The following is a description of a gene set: Reactome Pathway: Interleukin-1 family signaling part of: Signaling by Interleukins studied in species Homo sapiens The Interleukin-1 (IL1) family of cytokines comprises 11 members, namely Interleukin-1 alpha (IL1A), Interleukin-1 beta (IL1B), Interleukin-1 receptor antagonist protein (IL1RN, IL1RA), Interleukin-18 (IL18), Interleukin-33 (IL33), Interleukin-36 receptor antagonist protein (IL36RN, IL36RA), Interleukin-36 alpha (IL36A), Interleukin-36 beta (IL36B), Interleukin-36 gamma (IL36G), Interleukin-37 (IL37) and Interleukin-38 (IL38). The genes encoding all except IL18 and IL33 are on chromosome 2. They share a common C-terminal three-dimensional structure and with apart from IL1RN they are synthesized without a hydrophobic leader sequence and are not secreted via the classical reticulum endoplasmic-Golgi pathway. IL1B and IL18, are produced as biologically inactive propeptides that are cleaved to produce the mature, active interleukin peptide. The IL1 receptor (IL1R) family comprises 10 members: Interleukin-1 receptor type 1 (IL1R1, IL1RA), Interleukin-1 receptor type 2 (IL1R2, IL1RB), Interleukin-1 receptor accessory protein (IL1RAP, IL1RAcP, IL1R3), Interleukin-18 receptor 1 (IL18R1, IL18RA), Interleukin-18 receptor accessory protein (IL18RAP, IL18RB), Interleukin-1 receptor-like 1 (IL1RL1, ST2, IL33R), Interleukin-1 receptor-like 2 (IL1RL2, IL36R), Single Ig IL-1-related receptor (SIGIRR, TIR8), Interleukin-1 receptor accessory protein-like 1 (IL1RAPL1, TIGGIR2) and X-linked interleukin-1 receptor accessory protein-like 2 (IL1RAPL2, TIGGIR1). Most of the genes encoding these receptors are on chromosome 2. IL1 family receptors heterodimerize upon cytokine binding. IL1, IL33 and IL36 bind specific receptors, IL1R1, IL1RL1, and IL1RL2 respectively. All use IL1RAP as a co-receptor. IL18 binds IL18R1 and uses IL18RAP as co-receptor. The complexes formed by IL1 family cytokines and their heterodimeric receptors recruit intracellular signaling molecules, including Myeloid differentiation primary response protein MyD88 (MYD88), members of he IL1R-associated kinase (IRAK) family, and TNF receptor-associated factor 6 (TRAF6), activating Nuclear factor NF-kappa-B (NFκB), as well as Mitogen-activated protein kinase 14 (MAPK14, p38), c-Jun N-terminal kinases (JNKs), extracellular signal-regulated kinases (ERKs) and other Mitogen-activated protein kinases (MAPKs)., and this is the list of marker genes: IKBIP, UBC, N4BP1, PSMD1, RELA, SIGIRR, IL1F10, PELI1 (NCBI Gene Id 57334), IL1RAP, BTRC, RBX1, NFKB2, IL18BP, SEM1, ALOX5, NOD1, PELI3, PTPN18, PTPN2, TAB2, IL1R2, USP14, MYD88, IL1RAPL1, SQSTM1, NFKBIB, PSMD11, IL1RL2, MAP2K4, TIFA, PSMD6, SAA1, PSMC4, IL13, PSMA1, ALPK1, IL37, STAT3, HMGB1 (NCBI Gene Id 3146), PSMB7, S100B (NCBI Gene Id 6285), IRAK3, TBK1, CASP8, MAP2K1, IL18RAP, RIPK2, PSMB5, LRRC14, NKIRAS2, FBXW11 (F-box and WD repeat domain containing 11), PTPN11, TAB1, UBE2N, TRAF2, PELI2, NKIRAS1, PTPN4, CUL1, UBA52, PSMD7, NLRC5, PSMC5, TAB3, PSMD12, CHUK, PSMB1, IL1A, PTPN7, MAP2K6, MAPK8, IL33, USP18 (NCBI Gene Id 11274), TNIP2, TRAF6, CTSG, TP53, PTPN14, PSMA2, IL36G, IL18R1, PSMC1, PTPN23, PSMD2, IKBKG, MAP3K8, APP, IKBKB, IRAK4, PSMB3, IL1B, PTPN13, SMAD3, IL18, S100A12 (S100 calcium binding protein A12), PSMD8, PTPN12, PSMA3 (proteasome 20S subunit alpha 3), PTPN6, SKP1, PSMD13, PSMD14, MAP3K7, PSMC6 (proteasome 26S subunit, ATPase 6), IRAK2, IL36RN, PSMA6, CASP1, PSMC2, NLRX1, IL1R1, IL1RL1, NFKBIA, PTPN9, RPS27A, PSMA7 (NCBI Gene Id 5688), IRAK1, PSMA4, PSMC3, IL36B, PSMB6, UBB, PSMA5, N, MAP3K3, PSMD3, PSMB2, ADRM1, IL1RN, IL4, AGER, GSDMD, NOD2, PTPN5, TOLLIP (toll interacting protein), PTPN20, PSMB4, NFKB1 (NCBI Gene Id 4790), UBE2V1, IL36A